The following is a description of a gene set: Mouse Gene Set: GOCC_FEMALE_GERM_CELL_NUCLEUS The nucleus of the female germ cell, a reproductive cell in females. studied in species Mus musculus, and this is the list of marker genes: H2bc1, Slc2a1, Fbxo43, Rfpl4, Pou5f1, Tbpl2, Hmgn1, Oosp2, Tbp, Lhx8, Yap1, Aire, Aym1, Stpg4, Hmgn2, Ncapd3, Dmrt1, Marcks, Kpna7, Sycp3, Aurka, Coil, Sycp2l, H2ac1, Gtf2b, H1f8, Scml1, Dnmt1